Given this list of marker genes JAK1, NAPSA, MORC4, TLE1, EHD4, IRAK1, GLIPR1, MARVELD2, HSD17B12, CTBP2, GLIS2, IGFBP4, GOLM1, IER3, ICA1, BCL3, DDX39A, CD9, SYPL1, CPA3, TIFA, CYFIP1, DNAAF4, RNF19B, PLPBP, PNP, RFLNB, FKBP1B, ORC2, HHEX, FFAR2, CD34, GK, VCL, TTPA, PRKAG2, MAP3K6, RETREG1, GKAP1, SFXN1, PCYT1A, FGF3, NRG4, IL10RB, EXO1, HSPA14, SYNCRIP, PTGER3, BEX4, SERF1A, MAPKAPK2, SLC4A10, FGA, KIF2A, NEDD4, GTF3C6, OSBPL5, MYADM, TES, ZWINT, ARL1, CD244, PODXL, GRB10, CNN2, RIPOR1, CAPN2, RGS18, VIM, BMP2K, OPTC, DEPTOR, P2RX4, NUDT7, DDIT4L, ANXA1, HMGA2, NLGN2, CMPK2, SNX18, MPHOSPH10, ARRB2, SELENOS, PLXNB2, COMT, CD44, TACC3, FSCN1, FUT8, CLEC10A, LRRC8C, PYGL (glycogen phosphorylase L), KCTD14, TSC22D1, EME1, NME2, RAB43, STEAP3, BTK, PHACTR2, CTSK, ACSL1, ARHGAP6, DYRK3, SLC16A7, SERPINB1, STBD1, L2HGDH, LIN28A, PTPRE, CA13, FLNA, DOCK7, TAS1R1, TAL1, EGLN3, CDKN1A, LARS1, GGT1, UCHL1, CDH5, IGDCC4, MED7, FGD2, CD300LF (NCBI Gene Id 146722), SLC4A1AP, LRRK1, DNMT3B, HNF4A, XRCC2, THEMIS2, HBEGF, BCL11A, NFIX, TJP2, CLNK, NRK, PSMD11, SLC17A1, GNG12, PARP2, CST7, MAP2K3, TMT1A, OGFRL1, ALOX5AP, ADGRG3, PLCG2, F2R, AQP9, PAK1, PTGR3, MT1E, PARP16, ARHGEF2, RAB31, SLC25A24, RBP1, DAPP1, IKBIP, CLEC4D, IDE, ITIH5, ASAH1, PANK1, B4GALT6, PPIC, APPL2, NFE2, FASTKD1, RAI14, P2RY14, ZIK1, OXCT1, EPB41L4B, CCNH, C1orf54 (NCBI Gene Id 79630), PTGES3, GYS1, CDCA7L, LYL1, PLSCR1, TUBB4A, TF, GPR65, CKAP4, DENND5A, FAM111A, MAP7D1, ARAP3, AMPD2, MGAT4B, GZMB, CREG1, ADAM8, STAT3, FBXO33, GLUL, ARHGAP18, IQGAP2, here is a description of the gene set: species: Homo sapiens Development of T-cells provides a unique opportunity to study cell-fate determination due to the accessability and the well defined stages of developmental stages. In order to understand the genetic programs underlying fetal and adult T‑cell fate specification we subjected highly purified fetal and adult T-cell progenitor populations to a genome‑wide transcriptional analysis. The aim was to identify molecular elements that govern T-cell fate specification as a whole but ultimately to isolate elements that were specific for a given population in a specific developmental window. Genes up-regulated in comparison of fetal DN2 thymocytes versus fetal DN3 thymocytes. Human Gene Set: GSE24142_DN2_VS_DN3_THYMOCYTE_FETAL_UP from publication Belyaev NN, Biró J, Athanasakis D, Fernandez-Reyes D, Potocnik AJ (PMID 22581009)